Given this list of marker genes SUOX, ETHE1, TST, SQOR, SLC25A10, TSTD1, here is a description of the gene set: species: Homo sapiens While the human body is very economical with sulfur amino acids (SAA), superfluous SAA are degraded via cysteine to toxic hydrogen sulfide which must be dealt with. The pathway to oxidize this gas is localized to mitochondria and is highly conserved, pointing back to a time when life was immersed in sulfide-rich waters.<br>The pathway for sulfide oxidation consists of five reactions, one of which, the sulfur transfer from thiosulfate to glutathione, is still to be characterized fully. A mutation in one enzyme has been identified that is associated with ethylmalonyl encephalopathy and where tissue sulfide is elevated (Stipanuk & Ueki 2011). Reactome Pathway: Sulfide oxidation to sulfate part of: Degradation of cysteine and homocysteine